The following is a description of a gene set: Human Gene Set: GSE17721_PAM3CSK4_VS_GADIQUIMOD_0.5H_BMDC_UP mouse primary BMDCs were stimulated with tlr ligands and gene expression changes were profiled on Affymetrix arrays Genes up-regulated in comparison of dendritic cells (DC) stimulated with Pam3Csk4 (TLR1/2 agonist) at 0.5 h versus DC cells stimulated with Gardiquimod (TLR7 agonist) at 0.5 h. from publication Amit I, Garber M, Chevrier N, Leite AP, Donner Y, Eisenhaure T, Guttman M, Grenier JK, Li W, Zuk O, Schubert LA, Birditt B, Shay T, Goren A, Zhang X, Smith Z, Deering R, McDonald RC, Cabili M, Bernstein BE, Rinn JL, Meissner A, Root DE, Hacohen N, Regev A (PMID 19729616) studied in species Homo sapiens, and this is the list of marker genes: FAM120A, SMU1, SPAG4, SERPINF1, MAP7 (NCBI Gene Id 9053), LRWD1, BCAN, FTL, JUND, IL1RL1, KLHDC3, G3BP2, AKAP10, BEX1, MITF, KDM4C, RARB, CNPY2, DDO, IGLL1, AMPD2, H6PD (hexose-6-phosphate dehydrogenase/glucose 1-dehydrogenase), KRT33B, TAF7, PCDHB2, POLR3D, TNF, QPRT, CEMIP (NCBI Gene Id 57214), CASQ1, DDR2, MRPS33, KIAA1191, SYT12, ATAD2B, PCYT1A, CLDN3, NFIB, ACVR1, NLRP3, RBMS1 (NCBI Gene Id 5937), NFKBIE, CHPF, TCP11, ATP1B1, B4GALT7, ASB15, ACOT1, IL36A (NCBI Gene Id 83004), CCDC71L, KCNH2, BAIAP2, TAS1R2, CASP2, PARD6A, UNC93B1, TC2N, WNT3A, SPESP1, COX6B2, VIL1, EGR1, ERRFI1 (ERBB receptor feedback inhibitor 1), BRS3, GRPEL2, CXCL3, COPB2 (COPI coat complex subunit beta 2), DALRD3, H1-6, TP63, KEL, NOP16, MRPS5, CTTNBP2NL, ANO1, ADTRP, MRPL41, RPF2, SCYL1, SYNJ2BP, PEX3, ABCB4, SOD2, NBL1, COX6B1, GNG13, GANAB, DDR1, AGL, IL17RC, KRIT1, BLOC1S4, PHF20L1, E2F3, EEF1E1, CISH, TLR1, OR52A1, CCL13, TRAPPC14, SP7, PTPRS, HSP90B1, DCAF12, TXNDC8 (thioredoxin domain containing 8), HOXC6, CALML5, PPBP, CXCL2, PLLP, IER3, UBXN10, PROM2, THBS3, SAMD11, PRDM1, CAPN8 (calpain 8), NAPB, POT1, TBL2, GJB2, ARID5B, PYY, HOXA3, TUBGCP4 (NCBI Gene Id 27229), KRTAP20-2, TPTE, R3HCC1, ILF3, HSD17B7, RANBP1, MKRN3, RAG1, FAM86B2, PCDH7, SLC8A1, TFPI2, PCDHB5, CD244 (NCBI Gene Id 51744), FTSJ3, PTGER2, SLC23A1, CPEB1, HVCN1, IL10RB, PTPRE, ITGAX, GPR12, H1-10, PLGRKT, PER1, ABCG2, PRKCB, TOR2A, PLG, MRC2, MANF, NPC1 (NPC intracellular cholesterol transporter 1), CYSTM1, CD46, TLR2, SLC15A3, PHACTR2, GPR88, PDAP1, ALDH6A1, UBC, UNC13A, ENPEP, TRPM1, HS2ST1, GPN3, PTGR1, AMELX, H2BC5, ACTL7A, GDI1, NCAN, FKBP11, APC, CRYBA2, FGD4, NCDN, IL10RA, LAMA4, GRIN2C, CASKIN2, CHD7, CLYBL, ELK4, NOS2, SKA2, RHBDL3, SPAG5, HDAC2, GPT2, SIX4, CNGA1, IL6ST, TNRC6A